Given this list of marker genes Dtymk, Nme2 (NCBI Gene Id 18103), Shmt1, Nme3, Cmpk2, Tyms, Dctd, Cmpk1, Nme1, Dut, Tbpl1, Dhfr (dihydrofolate reductase), Shmt2 (serine hydroxymethyltransferase 2 (mitochondrial)), here is a description of the gene set: studied in species Mus musculus Mouse Gene Set: GOBP_PYRIMIDINE_DEOXYRIBONUCLEOTIDE_BIOSYNTHETIC_PROCESS The chemical reactions and pathways resulting in the formation of a pyrimidine deoxyribonucleotide, a compound consisting of nucleoside (a pyrimidine base linked to a deoxyribose sugar) esterified with a phosphate group at either the 3' or 5'-hydroxyl group of the sugar.